The following is a description of a gene set: Mouse Gene Set: GOBP_NEGATIVE_REGULATION_OF_GLUCOCORTICOID_SECRETION studied in species Mus musculus Any process that stops, prevents or reduces the frequency, rate or extent of glucocorticoid secretion., and this is the list of marker genes: Ptpn11, Cry1, Nrg1, Cry2, Tspo